Given this list of marker genes AMHR2, SMAD5 (SMAD family member 5), AMH, SMAD9, ACVR1, BMPR1B, SMAD1, SMAD4, BMPR1A, here is a description of the gene set: Human Gene Set: KEGG_MEDICUS_REFERENCE_AMH_SIGNALING_PATHWAY Pathway Definition from KEGG: AMH -> (AMHR2+(ACVR1,BMPR1A,BMPR1B)) -> (SMAD1,SMAD5,SMAD9) == SMAD4 species: Homo sapiens AMH signaling pathway. Pathway ID: N01454. Pathway type: Reference. Pathway class: nt06507 TGFB signaling.